The following is a description of a gene set: We used gene expression profiling, mutation analyses of FGFR3 and TP53, and LOH analyses of chromosome 9 and the TP53 region on chromosome arm 17p, to molecularly characterize 75 Ta and T1 bladder carcinomas. We identified four major cellular processes related to cell cycle, protein synthesis, immune response, and extra cellular components that contribute to the expressional heterogeneity of early-stage urothelial cell carcinoma (UCC). Activating FGFR3 mutations were found at the highest frequency in G1 tumors (80%), and showed a strong correlation with FGFR3 expression. In contrast, G3 tumors displayed mutations in less than 10% of the cases and a low level of FGFR3 expression. Even though LOH on chromosome 9 was not associated with any specific expression pattern, our data indicate that loss of chromosome 9 is associated with tumor development rather than initiation. The combined analyses suggest the existence of two types of UCC tumors, one which is characterized by FGFR3 mutation or expression, high expression of protein synthesis genes, and low expression of cell cycle genes. Furthermore, the presented data underscore FGFR3 receptor involvement in urothelial cell transformation as the presence of FGFR3 mutations has a major impact on the global gene expression profile of bladder carcinomas. Human Gene Set: LINDGREN_BLADDER_CANCER_HIGH_RECURRENCE Genes up-regulated among the high recurrence rate urothelial cell carcinoma (UCC) tumors. species: Homo sapiens from publication Lindgren D, Liedberg F, Andersson A, Chebil G, Gudjonsson S, Borg A, Månsson W, Fioretos T, Höglund M (PMID 16532037), and this is the list of marker genes: PTMS, H1-0, RHBG, UBR4, VCAN, MCAM, RPS19BP1, MYL9, DCAF7, COL5A2, NR4A1, LAMA4, COL1A2, PRRX1, COL4A2, ICAM3, MOB3A, CSRP1, CRIP1, ADAM19, FYN, ADGRE5, SPARC, BIRC3, IL32, CDK2AP1, VCAM1, LGALS1 (galectin 1), SERPINH1, MYLK, DPP7, AEBP1, PELO (pelota mRNA surveillance and ribosome rescue factor), PAPPA, IL7R, NDRG2 (NCBI Gene Id 57447), ANXA6, HTRA3 (NCBI Gene Id 94031), NRP2, MICAL2, COL18A1, MSN, PLCB4, MGP, ABI3BP, DNMT3B, NAV2, NID2, MYADM